The following is a description of a gene set: studied in species Mus musculus Mouse Gene Set: GOBP_RESPONSE_TO_FRUCTOSE Any process that results in a change in state or activity of a cell or an organism (in terms of movement, secretion, enzyme production, gene expression, etc.) as a result of a fructose stimulus., and this is the list of marker genes: Ppara, Srebf1, Ptgs2, Pck1, Tnf, Xbp1, Khk, Adipor2, Slc2a5, Slc26a6, Gckr